Given this list of marker genes CDKN1A, ERN1, CYP51A1, DEDD2, HERPUD1, CEMIP2, LY6E, IRF4, INPP4B, UBC, TMEM97, IL21R, RGS16, MACROH2A1, PPP3CC, FGL2, SPRY1, QSOX1, PTK2B, SYTL2, CISH, F2R, SLC16A10, PPP1R15A, ITK, PIP5K1B, HIF1A, B4GALNT4, NFKBIA, SQSTM1, SLC41A2, DTX4, PYGL, ATF3, TNFRSF1B, RGS10, ZFP36L1, WNK1, TGFBR3, PTPRJ, CBX4, UGCG, ILDR1, CTLA4, IFI44, ARHGAP39, AHI1, ADGRG1, SQLE, EHD1, TNFSF10, SORL1, ADAP1, RNF149, TJP1, TNF, ATP2B4, NFKBIE, EYA2, MAPKAPK3, SLC39A4, EXT1, IL2RA, NFIL3, ARHGEF12, STAT2, ISG20, XBP1, SLC7A5, LY6G5B, GFI1, CXCR6 (C-X-C motif chemokine receptor 6), PRDX6, DNAJB1, TIGIT, RBPJ, RNF213, TSPAN3, GADD45B, ARID5A, HSP90AB1, SURF4, ST8SIA1, ICOS, NR4A3, FTH1, INPP5F, SIPA1L1, TNFSF13B, PHLDA1, PRKCH, DUSP2, SLC3A2, NEURL3, SNX9, MT1A, MDFIC, LGALS3BP, QPCT, PDE4B, ENTPD1, TRIM14, ABHD4, LAG3, LAMC1, LRRC8D, ETS2, CDH1, GABARAPL1, ZNRF1, MKI67, GLRX, KIF15, UBE2S, ZFP1, CORO2A, IFITM3, PIK3AP1, PPP1R16B, NEDD9, H2AX, RRAD, BHLHE40 (basic helix-loop-helix family member e40), RGS1, BAG3, ARRDC3, TTC39C, RGS2, MXD1, CD101, GPR171, ITGA1, HASPIN, IFITM2, GRINA, CCL4, HIP1, GTF3C1, MFSD10, TLCD1, ITGAE, CREM, HPGDS (hematopoietic prostaglandin D synthase), NEK6 (NIMA related kinase 6), PMEPA1, ABR, CD86 (CD86 molecule), CLIC4, ATP6V0D1, TOB2, CXCL10, EGR1, STAT3, NUP98, SSBP2, FNDC3A, SPTY2D1, BAIAP2, ZYG11B, HSPA1A, DNAJA4, RFTN1, LMNB1, RHOB, BTG2, ADAM8, CCNI, FOSL2, APLP2, SIRT1, JUN, SLC39A6, ARSB, ICAM1, ITM2C, SMOX, PTGER4, IER5, MVB12B, ZFP36, ADAM19, SELENON, PDCD1, TRIB1, SLC16A6, DOCK9, GNG2, FMNL3, SKIL (NCBI Gene Id 6498), TRAF4 (TNF receptor associated factor 4, NCBI Gene Id 9618), here is a description of the gene set: Human Gene Set: GSE7219_UNSTIM_VS_LPS_AND_ANTI_CD40_STIM_NIK_NFKB2_KO_DC_DN from publication Lind EF, Ahonen CL, Wasiuk A, Kosaka Y, Becher B, Bennett KA, Noelle RJ (PMID 18566401) Genes down-regulated in dendritic cell NIK NFkB2-KO versus dendritic cell NIK NFkB2-KO LPS and anti-CD40 stimulated. This study aims at identifying genes that are NIK/NF-kappaB2 responsive in murine dendritic cells matured in vivo. species: Homo sapiens